Given this list of marker genes EPHB3, SLIT2, NDP, ALCAM, SEMA4F, VEGFA (vascular endothelial growth factor A), SLIT1, EPHA7, ISL1, RPL24, ISL2, PTPRM, ATOH7, POU4F3, NRCAM, EFNA5, EPHB2, PTPRO, NRP1, EPHB1, POU4F2, BMPR1B, ROBO2, here is a description of the gene set: Human Gene Set: GOBP_RETINAL_GANGLION_CELL_AXON_GUIDANCE studied in species Homo sapiens The process in which the migration of an axon growth cone of a retinal ganglion cell (RGC) is directed to its target in the brain in response to a combination of attractive and repulsive cues.